Given this list of marker genes Nt5c3, Upp2, Tbpl1, Tyms, Nme1, Dctd, Cda, Cmpk2, Shmt2, Nme2, Nme3, Dpyd, Nt5m, Cmpk1, Dhfr, Nt5c, Tymp, Upp1, Shmt1, Dctpp1, Dtymk, Upb1, Dpys, Dut, here is a description of the gene set: Mouse Gene Set: GOBP_PYRIMIDINE_DEOXYRIBONUCLEOTIDE_METABOLIC_PROCESS studied in species Mus musculus The chemical reactions and pathways involving a pyrimidine deoxynucleotide, a compound consisting of nucleoside (a pyrimidine base linked to a deoxyribose sugar) esterified with a phosphate group at either the 3' or 5'-hydroxyl group of the sugar.